The following is a description of a gene set: Mouse Gene Set: REACTOME_TGF_BETA_RECEPTOR_SIGNALING_ACTIVATES_SMADS species: Mus musculus TGF-beta receptor signaling activates SMADs, and this is the list of marker genes: Stub1, Ube2m, Tgfb3, Ubb, Nedd8, Mtmr4, Tgfbr3, Ltbp3, Smad2 (NCBI Gene Id 319898), Zfyve9, Itgb6, Bambi, Tgfbr2, Itgav, Itgb3 (integrin beta 3), Fkbp1a, Ltbp1, Strap, Rps27a, Smad4, Uba52rt, Smad3, Tgfb2, Uba52, Ltbp4, Cbl, Tgfbr1, Itgb8, Pmepa1, Fbn1, Itga8, Ltbp2, Smurf2, Ubc, Itgb1, Smad7, Tgfb1, Furin